The following is a description of a gene set: Any process that modulates the frequency, rate or extent of attachment of a cell to the extracellular matrix. Mouse Gene Set: GOBP_REGULATION_OF_CELL_MATRIX_ADHESION species: Mus musculus, and this is the list of marker genes: Thy1 (thymus cell antigen 1, theta), Myoc, Plpp3, Smad3, Ilk, Mmp12 (NCBI Gene Id 17381), Disc1, Dusp22, Mmp14, Enpp2, Kdr, Ptk2, Trem1, Hrg, Dlc1, Ccl21b, Gpm6b, Ccl21a, Cask, Limch1, Ccl25, Src, Itgb1bp1, Prkcz, Rin2, Dmtn, Ddr1, Fam107a (NCBI Gene Id 268709), Adam15, Rac1 (NCBI Gene Id 52352), Fut1, Cd36, Dapk3, Utrn, Myh9, Serpine1, Rcc2, Tek, Epb41l5, Postn, Wdpcp, Plau, Vcl, Lrp1 (low density lipoprotein receptor-related protein 1), Ptpra (NCBI Gene Id 19262), Col16a1, Acvrl1, Dusp3, Nf1, Phldb2, Efna5, Cfl1, Bcl6, Fmn1, Efemp2, Rasa1, Wnt4, Cdk6, Map4k4, Sema3e, Bcl2, Ninj1, Ajap1, Nexmif, Pik3cb, Epha3, Gfus, Ccl21d, Ptpn11, Dag1, Skap1, Epha1, Onecut2, Actg1, Dicer1, Clasp1, Macf1, Nrp1, Fermt1, Cripto, Sec1, Gsk3b, Onecut1, Coro1c, Poldip2, Bst1, Emp2, S100a10, Pkhd1, Rras, Camsap3, Plekha2, Abl1 (NCBI Gene Id 98922), Jup, Acer2, Peak1, Itgb3, Ppm1f, Sdc4, Thbs1, Plet1, Ldb1, Fermt2, Vegfa, Clasp2, Arhgap6, Jag1, Slk, Pcsk5, Hoxa7, Iqgap1, Pik3r1, Csf1, Grem1, Pten (NCBI Gene Id 70161), Cdkn2a, Dmd, Cd3e, Ccl28, Muc4, Lims1, Rhod, Myf5, Cdh13 (NCBI Gene Id 74373), Rock1, Ccl21f, Ccl21e, Tsc1, Cib1, Ptprj, Mink1, Ptk2b, Apod